Given this list of marker genes Ext2, E230029C05Rik, Rxrb (retinoid X receptor beta), Nup50, Cela2a, Gpr155, Noc2l, H2bc18, Cep120, Spata1 (spermatogenesis associated 1), 1700023H06Rik, Ehmt2, Adk, Rin3, Zfp335os, Tspan2, Gm15816, Ankle2 (NCBI Gene Id 71782), Foxj3, Slc26a2, Slc6a2, Ctnnal1, Kcnt1, 6030442K20Rik (NCBI Gene Id 77876), Fchsd2, Dcaf8, H3c3, Kdm1a, Tmem171, Gbp7, Dcun1d4, Cisd1, Plek2, Rassf1, Gm11536, Sdf4, Casp4, H3c13, Slc43a2, H3c10, Rptor, Mir26a-1, Pcmt1, Fbxo8, Map3k8, Thap7, Zfp672, Actn4, Rpl35a, Rras2, Dph6, Gm6658, Tgif2, Ehmt1, Plekhd1os, A430093F15Rik, Clec2d, Mcidas, Stxbp5, 1110008E08Rik, Acaa2, Arhgef40, Itgav, Gm11423, Zfp711, Sbf2, Tpcn1, Pcsk4, Gm8495, Frg2f1, Krt83, Mafg, Sdk1, Hadha, Tenm3, Stk32a, Ppara, Card10 (caspase recruitment domain family, member 10), Fbxl21, Dffb, Actr10, Nhlrc3, Pdgfa, Tbata, Rab3il1, Gorab, Chic2, Gm16731, H4c9, H2bc15, Snord3a, Actg1, Nfatc4, Clhc1, Dusp10, 2610037D02Rik, Tmem68, Hdac7, 5430402O13Rik, Ctnna2, Ext1, Phf12, Gm12915 (predicted gene 12915), Smad3, Tex30, Baiap2l2, Tmem184b, Nek8, Notch3, Lrp6, Nfyb, Smarca5, Atg4b, Tarbp1, Sobp, Tnfrsf11a (NCBI Gene Id 21934), Mylip, Nup85, Slc2a3, Rdm1, Man1b1, Otud7b, Tti2, Ssbp1, Nme6, Cbfb, Supv3l1, 9330154J02Rik, 2310061I04Rik (RIKEN cDNA 2310061I04 gene), Rwdd2b, Gm26444, Mbp, Epha2, Ciart, Wtip, Ap3d1, Arrdc3 (arrestin domain containing 3), Sfi1, Pacrg, Midn, Mrpl33, Ptrhd1, Eif5a, Cwh43, Ythdf2, Myo5c, Pip5k1c, Usp13, Marchf4, Cfap20dc, Hes1, Psmg4, Gphn, Sp1 (trans-acting transcription factor 1), Cbx3 (NCBI Gene Id 12417), Myl4, H4c3, Scarna17, Ptpn22, Rpl13, Smu1, Sp3, H2ac11, Upf1, Plec, Jmjd1c, Kics2, Taf9, Gm13610, Gm15908, Ep400, Mtag2 (metastasis associated gene 2), Arhgef1, Adprm, Cd248, Wwp1, Shisal2a, Foxo1, Ndufc1 (NADH:ubiquinone oxidoreductase subunit C1), Slc39a11, Plch2, Lsm7, Srd5a1, Tsc22d1, Thap4, Cebpg, Cntnap3, Yif1a, Snora78, Herc4 (NCBI Gene Id 78516), Dnal1, Cenpo, Rpain, Gm9887 (predicted gene 9887), Abhd17c, Ankrd13c, Ugcg, Gm2822 (NCBI Gene Id 100040524), Csnk1a1, B130046B21Rik, Ezr, H4c16, Brox, Brat1, Polh, Brpf3, Ssh1, Gm26708, Eif2b3, Gng5, Ripor2 (NCBI Gene Id 76622), Zbtb1, Rtca, Plekha7, Ablim2, H2bc26 (NCBI Gene Id 97778), Atp7b, H2ac7, Ctbp1, Pllp, Akt1, Epn1, Bcorl1, Psmd12, Zcchc14 (NCBI Gene Id 142682), Dbp (D site albumin promoter binding protein), Snord68, Phyhipl, Entpd2, Patj, Cep104 (centrosomal protein 104), Eed, Zdhhc24, Cytip, Kcnk15, Plaat5, Lrrc63, Znrf1, Alkbh5, Mrpl9, Gtpbp3, Josd1, Lhb, Col2a1, Mllt6, Gm27162, Lrba, Dctn1, Vstm2b, Pacsin3, Med12l, Psmg1, Trp53i13, H4c14 (H4 clustered histone 14), Lcp1, Sh2b3, Rnf144a, Prelid3b, Creld1, Ppp5c, Cxcl10, Zmiz2, Lrrfip1, Lrp8os3, Pheta2, Padi4, Meis2, H3c11, Fstl3, Syne2, Gm11613, Rbm39, H2bc3, Proser1, Trp53i11, Tex14, Gm20652, Slc35a4, Coro1c, Serf1, Sugp2, Cemip, Gm11847, Snora64, Ldlrad3, Etv6, H1f4, Nr2f1, Dtwd2, Hoxd11, Zbtb2, Ube2d2b, Tnik, D630045J12Rik, Tamm41, Gm14379, Ccdc107, Eif6, Rab35, H2bc6, H2ac4 (NCBI Gene Id 319172), A830082K12Rik, Armc6, Trap1, Bmp1, Hmg20b, Zbtb7a, H2ac25, Ptbp3, Wdhd1, Mtss2, H2ac6, Dnajc25 (DnaJ heat shock protein family (Hsp40) member C25), Exosc5, Naa12, Il2ra, Arrdc4, Krtcap3, H3c2, Stab1, Wapl, Adamts18, Asap1, Iqcg, Zfp469, A930001C03Rik, Katnip, Polr3f, H4c18, Phf23, 1700001O22Rik, Alg11, Zfhx3, H2bc13, Clip2, Rsrp1, Gm27242, Hcn4, Hadhb, B530045E10Rik, Pin4, Ttc13, Cycs, Trim17, Camsap1, C030037D09Rik, Asns, Rmrp, Dact2, Hapln2, Zmiz1os1, Ktn1, Kat6b, Fastkd3, Lsm1, Pold2, Pi4kb, Gnas, Rps12, Llgl1 (NCBI Gene Id 16897), Hic1, 1700096K18Rik, Umodl1, Pak6, Hip1, Ece1, Smurf2, Gm22935, Tmco3, Tmem80, H2bc11, Vegfa, Cnpy1, Syt2, Jpt2, Rexo1, Ankrd28, Rps23, Cxadr, Rhod, Ube2s, Tlk1, Neurog2, H2ac15, Srm, Hp1bp3, Slc35e3, Gpr62, Gapvd1, Atp5f1c, Dnaja4 (DnaJ heat shock protein family (Hsp40) member A4), Six1 (NCBI Gene Id 20471), Cpeb1, Cggbp1, Tmod1, Tmem131l, Prkaca, Rps2, Setd1a, Tsc2, Cdc27, Shf, Sufu, Fzr1, Rfx3, Bms1, Gm3807, Stard10, Mir7228, Kdm2a, Iqcd, Rcor1, H2bc12, Lhx6, Adss2 (adenylosuccinate synthase 2), Phactr2, Gm12536, Rbpj, Bag4, Gm13344, Cldn12, Ttc8, 1600014C23Rik, Myo18a, Snord118, Zfp664, Adgrb2, Ap3m1, Mtrr, Nop58, Fam117a, Eif5, Ncln (NCBI Gene Id 78831), Prelid1, Uvssa, Ndufb10 (NADH:ubiquinone oxidoreductase subunit B10), Gm8000, Nup88 (NCBI Gene Id 630141), Hlf, Podxl2, Adamts16, Gbp8, Plagl1, Syne1, Gm28043, Mapt, H2ac8, Kmt2a, Recql, Foxl1, Gtf3c1, Pola2, H4c8, Rbbp5, Snord45c, Bicd1, Gm11335, Nelfa, Tlcd1, Kcnq2, Phlda2, Adsl, Ptprs, Nfe2l3, Rasl10b, Ighv12-3, D230022J07Rik (NCBI Gene Id 320471), Phf14, Gpr37, Gm13529, Meis3, Lrp8, Snhg9, Mef2a, Arid2, Pkp3, Patl1, St8sia6, Trim28, Cdk1, Ptbp1, Syce2, Dll3, Wnt6, P4ha2, Axin2, Arhgdia, Ifih1, Arid1b, Gm15927, Pigp, Prnp, Pcyt2, Plekhd1, Ecel1, Hmgb3, Fndc3a, Slc2a13, Dusp8, F630040K05Rik, Fam163a, Klre1, Mex3c (NCBI Gene Id 399620), Ccdc92, 4930417H01Rik, Itpr2, Celsr2, Arpc2, Mapkapk5, Mrgbp, Fam78a, Cd86, Polr2e, Nthl1, 2210411M09Rik, 1700008J07Rik, Kin, Arhgef2 (Rho/Rac guanine nucleotide exchange factor 2), B3galt5, Sall4, Mapk6, Gng7, Vars1 (NCBI Gene Id 22321), Dzank1, Stx12, Dmrtb1 (NCBI Gene Id 56296), Arhgap11a, Dync1li2, Rabggtb, Bcat1, Tsen2, A330102I10Rik, Agbl5, Rtl5, Alas1, Wnt5b, Zgpat, Zglp1, Arsg, Rab24, Actn1, Tcf3, Rnf128, Asph, Arfrp1, Trim26, Lamp2, Nt5c2, Fzd8, Agfg1, Slc35b1, Maneal, Gm13710, Knstrn, Rps18 (NCBI Gene Id 20084), 4930592C13Rik, Zfp786, 2810013P06Rik, Msl2, Sf1, 4933437G19Rik, Ttll1, Gipc2, Por, H2ac12, Ubr4, Stam2, Hoxd3os1, Susd1, Gm11398, H1f1, Gm2018, Gfra4, Caprin1, Nrsn1, Npnt (NCBI Gene Id 99581), Unk, Ing5, Yap1, Bach2it1, 4930507D05Rik, Afap1l1, Klhl22, Gm16283, 9130019P16Rik, H2bc7, St3gal5, Tbc1d14, Prn, 3000002C10Rik (RIKEN cDNA 3000002C10 gene), Ssbp4, Gm13033, Nsun2, Cep57l1, Dtnb, Gldc, Stat5a, Ndufa4, Tfeb, Atp8b1, Ovol1, Tpd52, Gm12125, Ppfia3, Fhdc1, Ttc3, Gm14261, Gtf3c6, Dnal4, Ankrd26, Gm23143, Diras2, Pxdc1, Gm15559, Dpysl3, Adrm1, Nxf1, H3c6, Vav1, Gm30292, Fam98c, Mir345, Synj2, Tkt, Gm16270, Slc39a7, Ace3, Pmaip1, Sf3a2, Ttyh3, Prkn, Abcb6, Rnf8, Slc22a15, Xpo5, H2ac5-ps, Irgq, Nuak1 (NUAK family, SNF1-like kinase, 1), Prickle1, Tor3a, Sco1, Slain1, Srrm2, 4933433G15Rik (RIKEN cDNA 4933433G15 gene), 1600023N17Rik, Srcap, Gdnf, Eya1, Vdac3, Runx2os2, Eef1d, Bckdha, Strbp, Suds3, H3c8, Sp3os, Hspa9, Slc35b4, Hs6st2, Ptpru, Mdm2, Snap91, Mapkapk3, Pnpla8, Med28, Csf2, Pomt1, Gm23119, Zfp609, Echdc1, Rec8, Pah, Fbxo31, Hs6st1 (NCBI Gene Id 50785), Zar1, Ccr9, Cops6, Rgs1, Hspa12a, Zc3h3, Exd2, Erlin1, Gm23130, Sesn1, Fbxw2, Selenot, Lrrk2, Zbtb25, Klhl10, Sppl2b, Sdk2 (NCBI Gene Id 75715), Smad5, Crlf3, Il7r, Sugct, Crtc1, Vwa7, Susd4, Rundc3a, Ppp1r16a, Nrn1, Otub2, Grcc10, Aida, Golt1b, Dut, Cherp, BC001981, Tbx15, Ndc80, Gadd45a, Cyp24a1, Slc25a29, Wipi2, Myo19, Zbtb17, Piezo1, H3c1, Abhd15, Hagh, Actn3, Dapk3, Surf6, Poldip3, Stk11, Tcf7l2, Tada1, Mir6538, Tigd5, Pheta1, Frmd4b, Zranb2, Nipbl, Cstad, Mst1r, Kctd17, Blcap, Mtarc1, Cic, H2bc8, Rpl34, Syk (NCBI Gene Id 20963), Msi2, Dpf1, Narf, H2bc4, Set, A230083N12Rik, 4930455B14Rik, A230077H06Rik, Vps54, Cep44, 4930500F10Rik, Gm15688, Tgs1, Them6, Nr3c2, Zc3h14, Ogdh, Daxx, Fxn (frataxin), Lemd3, Lacc1, Pum2, Ano8, Tnfsf18, Slit2, Ak6, H3c14, Depdc1b, Ankrd33b, Elmod1, 6530409C15Rik (NCBI Gene Id 76224), Gm22513, Tbc1d31, H4c2, Rps27a, Coro1a, Pdzd4, Zfp661, Nr6a1, Dlg3, Auts2, Dcaf13, Mlec, Txnl4a, Mir6236, Rad17, L3mbtl3, Hnrnph1, Reep6, Sys1, Gramd1a (GRAM domain containing 1A), Ctcf (NCBI Gene Id 270092), Usp27x, Slc25a23, 1700025A08Rik, Grb10, Snord13, Il21, Tnfrsf9, Dlk2, Ptp4a1, Vps52, Socs4, Mex3b, H3c4, Paqr7, BC028777, Pcbp2, Tspan13, Ccdc122, Cd2, Rpl38, Ccdc40, Caprin2, Rac1, Susd3, 2210408I21Rik, Wbp4, Gtf3c5, Sh3bp5l, Slc6a19, Nr1h2, BC051226, Cxxc1, Eef1a1, Arl6ip5, Atxn2l, 1110006O24Rik, Snx32 (sorting nexin 32), Dennd6b, Nt5c3b, Mrps5, here is a description of the gene set: Mouse Gene Set: HDAC4_TARGET_GENES studied in species Mus musculus Genes containing one or more binding sites for (Hdac4) in their promoter regions (TSS -1000,+100 bp) as identified by GTRD version 20.06 ChIP-seq harmonization. from publication Yevshin I, Sharipov R, Kolmykov S, Kondrakhin Y, Kolpakov F (PMID 30445619)